Given this list of marker genes Slc30a8, Slc30a1, Slc30a5, Slc9c1, Slc38a5, Slc9a4, Slc11a1, Letm1, Slc9a9, Slc17a7, Slc9a7, Slc17a6, Slc38a3, Tmco3, Slc9a2, Ghitm, Slc9a6, Slc30a2, Slc9b2, Slc9a8, Slc9a1, Slc9a5, Chp1, Slc9a3, here is a description of the gene set: Mouse Gene Set: GOMF_METAL_CATION_PROTON_ANTIPORTER_ACTIVITY studied in species Mus musculus Enables the transfer of a solute or solutes from one side of a membrane to the other according to the reaction: metal ion(in) + H+(out) = metal ion(out) + H+(in).